The following is a description of a gene set: Mouse Gene Set: ZHANG_UTERUS_C1_PROLIFERATIVE_STROMAL1_MGP_HIGH_CELL Table S2: Representative genes of each cell cluster from publication Zhang L, Long W, Xu W, Chen X, Zhao X, Wu B (PMID 35669188) species: Mus musculus, and this is the list of marker genes: Ms4a4d, Sparcl1, Ckb, Zfas1, Gm9794, Rps27, Ptma, Rpl34-ps1, Cst3, Rpl18-ps1, Trabd2b, Tuba1a, Gm7536, Calu, Rpl36a-ps2, Egr1, Myl12a, Aebp1, Eef1a1, Inhbb, Cavin3, Tppp3, Rps27rt, Rrbp1, Ltbp4, Snhg18, Igfbp6, Cmtm3, mt-Nd3, Laptm4a, Rhoc, Col5a1, Inmt, Marcks, Serpinf1, Adh1, Mfap4, Adprh, Des, Gm10073, Rbp1, Rps19-ps6, Msrb2, Igfbp3, Txnip, Lrp1, Cdh11, Prelp, Ckap4, Rpl9-ps6, Mif (NCBI Gene Id 17319), Serpine1, Nme2, Selenof, Col1a2, Rpl39-ps, Srm, Dcn, Herpud1, Rps15a-ps6, Matn2 (NCBI Gene Id 17181), Ogn, Hspa1a, Rps25-ps1, Gm4366, Rpl10-ps3, Dnajb1, Ccn1 (NCBI Gene Id 99596), Igf1 (NCBI Gene Id 320499), Rps18, Mmp23, Gpx8, Ssr4, Rarres2, Cd63, Dap, Bgn (biglycan), Ctsl, Tmem109, Mmp2, Plod2, Tceal8, Serping1, Fbln2, Gadd45g, Rps15a-ps7, Timp2, Mdk, Klf6 (Kruppel-like transcription factor 6), Rpl31-ps8, Rcn3 (NCBI Gene Id 78587), Pdia3, Gm10288, Hdlbp, Ebf1, Oxtr, Plk2, Jun, Arf4, Gm15772, Gm10076, Rpl35, Sdc1, Rnase4, A2m, Gm15500 (predicted pseudogene 15500), Cxcl12, Cdkn1c, Btg1, Mir703, Rps21 (NCBI Gene Id 76519), Rhob, C1qtnf3, Cpe, Rplp0, Tmed2, Pgrmc1, Ypel3, Tmt1a, Maf, Gm10177, Axl, Vapa, Eef1g, Scd2, Stmp1, Sox4, Pdia6, Anxa1 (annexin A1), Spcs1, Sec61a1, Sec61g, Mmp14, Mfap2, Gng12, Col3a1, Wipi1, Ppib, Atp8a1, Gm6136, Cd81, Dio2 (NCBI Gene Id 13371), Htra3, P4hb, Gstm1, Gm5905, Aldoa, Npc2, Maged1, Meg3, Wdr89, Gm9385, Atp6v0d1, Gm10736, Rpl4, Dpt, Rpl10, mt-Rnr2, Myl6, Fstl1, Vim, Oxct1, Fbln1, Rpl28-ps1, Tubb6, Ngfr, Gpx4, Ftl1-ps1, Col6a3, Rpl3-ps1 (NCBI Gene Id 674874), Rab6a, Tmed3, Rpl37rt, Map1lc3b, Dstn, Gm5835, Cald1, Rps23-ps1, Sparc, Anxa3, Serpinh1 (NCBI Gene Id 12407), Cd63-ps, Gm15427, Wnt5a, Ramp3, Lum, Angptl2, Rps10-ps2, Gm6863, Rpl10a-ps1, Hspa5, Sptssa, Spon1, Anxa2, Tnfrsf12a, Aldh1a2, Gm12174, Ppp1r15a, Mxra8, Spon2, Gas5, Serf2, Fn1, Sdk1, 2410006H16Rik, Ost4, Ramp2, Gm5805, Tcf4, Col5a2, Htra1, Pamr1, Lgals1 (NCBI Gene Id 16852), Rasd1, Rps13-ps2, Ddost, Uba52, Uba52rt, Cd248, mt-Rnr1, Fos, Tubb2a, Surf4, Map1lc3a, Loxl2, Nedd4 (NCBI Gene Id 639396), Ccl7, Ubc, Uqcrh, Col15a1, Ilk, Pnp, Tcf21, Sgk1, Tnfaip6, Prss23, Rps3a2, Rps6, Slc25a39, Arl4c, mt-Nd5, Ssr3, Fosb, Hsd11b2, Chchd10, Hspa1b, Cryab, Bst2 (bone marrow stromal cell antigen 2), Dusp1, Rcn1, Gapdh, Vkorc1, Eln, Ctsk (cathepsin K), Ddit4l, Vat1, Ggt5, Cope, Gja1, Scube1, Cstb, Hes1, Col6a4, Mmp11 (matrix metallopeptidase 11), Gpx3, Fxyd1, Gsn, Gm12481, S100a16, Gm4149, Gm6204, Col6a1, Tmem119, Mmp19, Maged2, Morf4l2, Gm7808, Rpl15, Gm3511, Tpt1-ps3, Fbn1, Kdelr2, 2310022B05Rik, Gm8730, Scpep1, Cnpy2, Gm9843, Cd164, Nbl1, Mfge8, Lox, Pttg1ip, Lsp1, Ift20, P2ry14, Eif4a2, Emb, Klf4, Anxa5, Errfi1 (NCBI Gene Id 74155), Swi5, Mfap5, mt-Co1, Nppc, Selenop, Ubb-ps, Adamts2, Rpl6l, Gm8797, Ech1, Kdelr3, Rps18-ps5, Rps26-ps1, Ctla2a, Cd34, Rps6-ps4, Pltp (NCBI Gene Id 18830), Gnas, Gm7600, Mgp, Ppic, Yipf5 (Yip1 domain family, member 5), Tmsb10, Selenos, Ier2, Gstp1, Gm11478, Gas1, Gas6, Gm13588, Gm13436, Cyb5a, Tpm4, Prkar1a, Ccl11, Raly (hnRNP-associated with lethal yellow), Gm14586 (predicted gene 14586), Gm5586 (predicted gene 5586), Tmem258, Rpl35rt, Rpl11 (ribosomal protein L11), Ctnnb1, Myl9, Gm14165, Crispld2 (NCBI Gene Id 78892), Sar1a, Col1a1, C1s1, Col6a2, Igfbp5, Ackr3, Gm14303, Dbi, Rpl14-ps1, Sec61b